Given this list of marker genes NKX3-1, NR4A3, RBPJ, LEF1, PRAME, COMMD6, DCAF1, ASAH1, BRD8, NKX2-1, CEBPA (CCAAT enhancer binding protein alpha), TBK1, PARP9, GTF2A1, STAT3, DNAJA1, TRIM24, TCF7L2, NOTCH2, MYOCD, FAM220A, GTF2I, MLXIPL, STRN, PIAS2, TCERG1, COMMD7, BHLHE40, PKN1, FOXP1, HEY1, NCOA2, MED17, SP1, GSC, KDM5D, NFKBIA, RAD23B, TRIP6, NRIP1, JUN, FBP1, HDAC3, FOS (NCBI Gene Id 2353), KAT8, DCAF13, MED16, KEAP1, CHD4, PPARGC1B, CITED2, EGR2, NR0B2, ZFPM1, LDB1, KDM3A, MAPK14, ID4, SRARP, ESRRB, HIF1AN, JUND, FOXL2, RNF6, GSK3B, PAGR1, PROX1, CD34, PCNA, DOT1L, PDX1, OASL, E4F1, GATA6, CRY1, ZNHIT3, WIPI1 (NCBI Gene Id 55062), HIPK2, ZBTB8A, BCL10, TADA3, NEUROD1, NR0B1, CDK5RAP3, EOMES, MEF2C, NFE2L2, DHX9, TBX3, MED12, JMJD1C, CREB1, TACC2, MLX, SPI1, NCOA6 (nuclear receptor coactivator 6), HEY2, RXRA, DACT1, HDAC2, XBP1, LHX3 (LIM homeobox 3), PPARGC1A, DNAJA3, SMARCB1, MDFIC, PITX2, NR1I2, NR1H4, EXOSC9, BBS1, NKX6-1, PRMT2, HCLS1, HDAC4, PARK7, KLF4, BBS2, SMARCE1, NKX2-5, TRIB1, FOXA2, ACTN4, SMARCA4, TAF11, CDKN2A, MTA2, LCOR, TP73, AIP, RBX1, DDIT3 (DNA damage inducible transcript 3), HMGA1 (NCBI Gene Id 3159), RNF14, PPID, CSNK2B, AR, BMAL1, ANKRD1, DLL1, PHB2, TAF6, NCOA1, ANKRD2, TAF1, CREBBP, PRDM13, DNAAF4, NPM1, VDR, MTDH, SP100, TAF4B, NCOR2, PRKCB, PPARA, POU1F1, SMAD3, SIN3A, MED25, RARB, TCF23, TBX6, MAD2L2, KDM4C, FOXP3, MYOD1, MMS19, HNF4A, SETD6, NCOA3, CRKL, SETD1A, TRIM68, SLC30A9, ANKRD42, TP53BP2, TEAD3, TOB2 (transducer of ERBB2, 2), UHRF2, ARNT2, GABARAPL1, TRERF1, ID2, SMAD2, SRF (serum response factor), PITX1, FAF1, PSMD10, RB1, TMF1, SDR16C5, HDAC1, GTF2A2, STING1, GATA4, JUP, HSPB1, BBS7, PPARD, DTX3L, MEF2A, HDAC9, NSD1, HMGB1, MED30, ATF4, SP3, H2BC9, POU4F1, HIF1A, SMAD4, EP300, CTNNB1, PSMA6, RERG, BRMS1, SNW1, MED24, UBXN7 (NCBI Gene Id 26043), ASXL1, DDX5, CPNE1, MED1, TACC1, TBX5, FIZ1, CRY2, TAF7, PPARG, TBX20, MED14, THRAP3, BCAS3, MED13, DDX54, LMO2, SMARCD3, GATA3, CNOT1, WWP2, ARID5A, HDAC5, XPC, ZBTB7A, PDCD11, STK4, TRIP4, CTDP1, CRX, TGFB1I1, ETS2, GATA2, TAF4, ISL1, MEF2D, EN2, MKKS, SPEN, ADD1, TAL1, BUD31, MED4, BAZ2A, TRIP12, SIRT1, HSF1, MIXL1, ATF2, C1D, TFDP3, LATS1, HES1, COMMD8, FOXC1, FKBP4, IFI27, GTF2H1 (general transcription factor IIH subunit 1), NR1H2, WBP2, ACTB, TCF21, GATA1, CTBP1, CIITA, YWHAH, CCDC62, NHLH2, GFI1B, DAXX, PARP1, ARNT, DUSP26, CEBPB, GBX2, HAND2, PADI2, STAT5B, NIF3L1, MTA1, GTF2B, KDM1A, AHR, TRIM32, BBS10, HES6, RBBP8, TP53BP1, NCOR1, BBS4, HMGN3, ANXA4, PRRX1, ZFPM2, RELA, HIRA, HAND1, HMGA2, DNMT3A (DNA methyltransferase 3 alpha), TBXT, POU5F1, ARID1A, EPAS1, AKAP8, ZNF366, PTPRT, SETD3 (NCBI Gene Id 84193), FOXH1, NR4A2, PTPN2, ESR1, NFATC1, TBP, BHLHE41, PRKDC, TTC8, ELK1, NR4A1, LRIF1, SMARCA1, DMAP1, NCOA7, FLT3, ETS1, TCF3, FAM220BP, RARG, RNF25, TRIB2, TAF10, BBS5, SOX17, REST, TP53, CALR, here is a description of the gene set: Binding to a sequence-specific DNA binding RNA polymerase II transcription factor, any of the factors that interact selectively and non-covalently with a specific DNA sequence in order to modulate transcription. Human Gene Set: GOMF_RNA_POLYMERASE_II_SPECIFIC_DNA_BINDING_TRANSCRIPTION_FACTOR_BINDING studied in species Homo sapiens